The following is a description of a gene set: Human Gene Set: HP_DELAYED_PROXIMAL_FEMORAL_EPIPHYSEAL_OSSIFICATION studied in species Homo sapiens Developmental delay of ossification of the proximal epiphysis of the femur. Delayed proximal femoral epiphyseal ossification, and this is the list of marker genes: RNU4ATAC (RNA, U4atac small nuclear), DUOX2, TG, LHX3, SLC5A5, TSHR, PROP1, TPO, DUOXA2, LHX4 (NCBI Gene Id 89884), POU1F1, TSHB (thyroid stimulating hormone subunit beta), COL2A1, IYD, B3GALT6, MATN3, HESX1 (NCBI Gene Id 8820)